The following is a description of a gene set: studied in species Mus musculus Any process that activates or increases the frequency, rate or extent of lymphocyte activation. Mouse Gene Set: GOBP_POSITIVE_REGULATION_OF_LYMPHOCYTE_ACTIVATION, and this is the list of marker genes: Il1a, Il3, Prkcz, Nod2, Stat5b, Ifng, Tnfsf9, Bcl2 (NCBI Gene Id 98734), Vnn1, Lgals8, Cd209d, Cav1, Cd47, Sox12, Cd5, Vcam1, Jak2, H2-Oa, H2-Aa, Itpkb, Pms2, Zp3, Irf1 (interferon regulatory factor 1), Igf2, Cd83 (NCBI Gene Id 12522), Tnfrsf14, Cyld, Fgf10, Xbp1, Rhoa, Ighm, Cd55b, Skint1, Efnb1, Il2rg, Tnfsf13b, Exosc3, Pagr1a, Tcf3, Pik3r6, Tgfb1, Rps3, Ephb2, Nsd2, Mad2l2, Aif1 (NCBI Gene Id 56250), Ticam1, Rara, Nkap, Tnfsf11 (tumor necrosis factor (ligand) superfamily, member 11), Tnip2, Il15ra, Cd81, Sox13, Msh2, Ccl21a, Actl6a, Tbx21, Clec7a, Pycard, Lilrb4b, Zbtb1, Vav1, Gli3, Dnaja3, Il18, Kmt5c, Cd28, Lgals9, Exosc6, Ephb4, Ppp2r3c (protein phosphatase 2, regulatory subunit B'', gamma), Havcr2, Nckap1l, Cd55, Itgal, Il23a, Bad, Zmiz1, Bcl10 (B cell leukemia/lymphoma 10), Nfkbiz, H2-Eb1, Ephb6, Igfbp2, Spta1 (NCBI Gene Id 98361), Gpr183, Dock8, Lyst, Stat5a, Mmp14, Flot2, Arid1a, Ppp3ca, Tlr9, Ptpn22, Il4ra, Hes1, Cd40, Dhps, Vsir, Cd1d2, H2-DMb2, Foxo3, Zbtb7b, Slc7a1 (NCBI Gene Id 264068), Adk (adenosine kinase), Phf10, Cd276, Efnb2, Irs2, Tnfrsf13c, Wnt10b, Stat6, Ripk2, Atp11c, Cdkn1a, Atad5 (ATPase family, AAA domain containing 5), Rasal3, Runx3, Myd88, H2-Ab1, Tgfbr2, Traf6, Smarcc1 (SWI/SNF related, matrix associated, actin dependent regulator of chromatin, subfamily c, member 1), Smarcb1, Icos, Tox (NCBI Gene Id 76569), Cd4, Nfkbid, Icosl, Sox4, Cyrib, Adam8, Card11 (caspase recruitment domain family, member 11), Nfatc2, Btk, Klhl25, Fadd, Bmi1, Cd160, Spn, Rasgrp1, Gpam, Clcf1, Pck1, Kmt5b, Tlr4, Mef2c, Cbfb, H2-DMa, Cd24a, Trp53bp1, Il15, Ptprc, Cd6, Ighd, Ddrgk1, Shb, Cd86, Pcid2, Ccl2, Slc4a1, Dusp10, H2-Ob, Il36b, Gas6, H2-Ea, Actl6b, Spi1, Cd209e, Ager, Il1b, Sash3, Cd320, Abl1, B2m, Bcl6, Cd209c, Arid2, Hmgb1, Socs5, Tnfsf13, Bloc1s3, Mlh1, Gimap5, Cd38, Opa1, Kat5, Prkaa1, Btn2a2, Anxa1, Cd59b, Sart1, Fcho1, Il12b, Pdcd1lg2, Ccl19, Gata3, Tnfsf14, Mpl, Ada, Hsp90aa1, Flt3l, Ulbp1, Rag1, Actb, Peli1, Tespa1, Prlr, Nr5a2, Smarcc2, Foxp3, Socs1, Zap70, Lep, Slamf1, Kitl, Tnfrsf4, Raet1d, Il1rl2, Cd59a, Smarcd3, Tyrobp, Syk, Wnt3a, Smarca2, Dpp4 (dipeptidylpeptidase 4, NCBI Gene Id 13482), Ep300, Egr3, Igf1, Il6st, Slc39a10, Akirin2 (akirin 2), Fbxo38, Cd3e (CD3 antigen, epsilon polypeptide), Blm, Csf1r, Runx1, Ccr7, Tirap, Il5, Ccdc88b, Sh3kbp1, Lilrb4a, Shld2, Irgm1, Ap3d1, Cd27, Smarcd2, Chrnb2, Epo, Bst1, Il12rb1, Coro1a, Tyk2, Cd80, Hlx, Ywhag, Il7r, Hps1, Nck2, Hspd1, Vav3, Zfp609, Cd74, Nck1, H2-Eb2, Lef1, Il4i1, Zfp335, Bloc1s6, Cd244a, Il13, Tfrc, Hsph1, Brd2, Cd274, Mif, Pnp, Il10, Il7, Tacr1, Abl2, H2-DMb1, Nlrp3, Rif1, Klhl22, Gimap3, Smarcd1, Ihh, Il6, Tnfsf4, Btnl2, Lck, Cd1d1, Pbrm1 (NCBI Gene Id 76748), Cd40lg, Ambra1, Prkcq, Paxip1, Il2ra, Shh, Rhoh, Sirpa, Il4, Il2 (NCBI Gene Id 16183), Cd46, Hmces, Lgals1, Mir326, Xrcc6, Ap3b1, Prkdc, Smarca4, Brd4, Mdk, Carmil2, Tac1, Shld3, Selenok, Ccr2, Shld1, Smarce1, Il21, Axl (NCBI Gene Id 26362), Xcl1, H2-T23, Malt1, Efnb3, Brd7, Thy1, H2-M3, Ccl5, Jak3, Inpp5d, Il12a, Vtcn1